The following is a description of a gene set: Human Gene Set: chr5q11 species: Homo sapiens, and this is the list of marker genes: PGAM1P1, KATNBL1P4, IL31RA, MIER3, ASS1P9, EMB (embigin), RPL5P15, RLIG1P1, GZMA, MOCS2, ENSG00000238326, CCNO-DT, PSMC1P4, MIR581, LINC02106, RNF138P1, C5orf67, RNU6-272P, RPL26P19, CSPG4BP, ARL15, SETD9, RNA5SP184, HSPB3, ENSG00000287709, RPL17P21, RMEL3, GPX8, ENSG00000289060, RNA5SP183, CDC20B, RNU6-299P, PLK2, RAB3C, ANKRD55, MCIDAS, LNCBRM, ISL1-DT, RPL37P25, IL6ST, B3GNTL1P1, NDUFB4P2, HMGB1P47, NDUFS4, PARP8, MFSD4BP1, LINC01948, LINC02118, LINC02101, ENSG00000289709, PLPP1, RN7SL801P, RNU6-480P, IL6ST-DT, MTREX, LINC02108, C1GALT1P2, RNU6-1296P, RPL13AP13, GZMK, SALL4P1, LINC02105, RNA5SP185, GZMAP1, PELO-AS1, ITGA2, ESM1, MAP3K1, SNX18, FST, ACTBL2, MIR449A, ISL1, DHX29, HMGN1P17, MIR449C, PELO, AK4P2, LINC02225 (long intergenic non-protein coding RNA 2225), HNRNPH1P3, SLC38A9, DDX4, ENSG00000249236, RPL17P22, ITGA2-AS1, MOCS2-DT, MIR5687, MIR548AE2, RPS17P11, RNU6ATAC2P, MIR449B, ITGA1, GAPT, CCNO, RNA5SP182, GPBP1